The following is a description of a gene set: part of: Neurotoxicity of clostridium toxins Reactome Pathway: Toxicity of botulinum toxin type D (botD) species: Homo sapiens Botulinum toxin type D (botD) is only very rarely associated with human disease and a pathway by which it might enter the circulation from the human gut has not been described. Nevertheless, the toxin itself, a disulfide-bonded heavy chain (HC) - light chain (LC) heterodimer (“dichain”), is capable of binding to neurons by interactions with cell surface ganglioside and synaptic vesicle protein 2 (SV2), the bound toxin can enter synaptic vesicles and release its LC moiety into the cytosol of targeted cells, and the botD LC can cleave vesicle associated membrane proteins 1 and 2 (VAMP1 and 2) on the cytosolic face of the synaptic vesicle membrane. These four events are annotated here., and this is the list of marker genes: SV2A, SV2B, VAMP2, SV2C, botD, VAMP1